The following is a description of a gene set: Human Gene Set: GOBP_RNA_DECAPPING studied in species Homo sapiens Cleavage of the 5'-cap of an RNA., and this is the list of marker genes: DCP1B, PNRC2 (NCBI Gene Id 55629), EIF4ENIF1, PAN3, CNOT7, ZFP36, DCP2, PATL2, LSM1, NOCT, EDC4, NUDT16, CAPRIN1, DXO, DCP1A, NUDT12, PATL1, EDC3 (enhancer of mRNA decapping 3), DCPS, NUDT3